Given this list of marker genes DIMT1, SCAI, ROR1, SSH2, AGPS, ATF1, KLHL24, HIF1A, BPNT2, SH3GLB1, PRRC1, PCDHB15, YWHAZ, SHPRH, FAM177A1, REV1, SLC9A1 (solute carrier family 9 member A1), DPY19L1, SLC19A2, ZNF704, MYC, B3GAT1 (NCBI Gene Id 964), ARGLU1, LEMD3, KLHL15, KPNA4, PALM2AKAP2, TRHDE, DYRK1A, TGDS, IRX2, UBE2D1, ZNF382, NAP1L1, CADM2, IGFBPL1, GPR155, IGFBP3, HYCC1, NSD2 (NCBI Gene Id 7468), ADNP, SREK1IP1, ABI1, ZNF682, TRIP12, PTPDC1, UBAC2, LIN7C, USP38, TET2, TMEFF2, CXCR4, SLC4A10, CNTNAP2, ABCA5, SORBS1, RANBP3L, TET3, PPM1K, CELF2, PIK3R3, VASP, ACVR1, GPC4, TC2N, CAMTA1, DYRK2, ARL14EP, UBN2, CBLL1, TTYH2, TCF7L2, CREBRF, EIF5A2, SKI, TBL1XR1, SMURF2, ZFHX3, USP46, HPS1, PIK3R1, ZEB1, GPATCH2, ZC3H12C, NRIP1, USP15, CTDSPL2, GPC6, SERTAD2, SERINC3, PTPRK, AKAP5, PTBP2, CLDN11, MTSS1, MARCHF4, SGMS1, PFKFB2, KANSL1L, MARCHF5, CDYL, FBXW2, COA5, PARP15, BEND4, FERMT2, INPP4A, TFPI2, PTPRZ1, CECR2, ZMPSTE24 (NCBI Gene Id 10269), MAFG, SRFBP1, OAS3, EPG5, ABHD13 (abhydrolase domain containing 13), LPP, MMD (NCBI Gene Id 23531), DIP2B, CD38, L2HGDH (NCBI Gene Id 79944), RANBP1, ABLIM2, YES1, SNW1, FGFR3 (NCBI Gene Id 55546), SAR1B, GNL3L, USP49, CCDC71L, AMER2, KCMF1, DNMT1, APH1A, FOS, PDE7A, SH3TC2, SLC38A1, TRIM36, GTF2B, NAA15, SLC16A7, SFPQ, NEK7, LHX9, MAPK8, MYBL1, GNB4, PPFIA1, SUZ12, DLEU7, SNX16, SAMD8, DTD1, SEH1L, FAM83B, HYCC2, SLC25A44, FARP1, RIMKLB, CSNK1A1, SINHCAF, DPP10, ZDHHC17, SCYL2, TOX, CTNND1, NAMPT, ADGRE2, PSD3, TMEM41B, EREG, YTHDF1, MSTN, RBPJ, SPOCK3, VPS13C, CYP2U1, ZBTB44, PRMT1, PTBP3, NAA50, SERPINB1, FBXL20, ZNF609, RAF1, TRIM33, SIDT2 (NCBI Gene Id 51092), DIS3L2, ST6GAL1, STRA6, RPRD1A, SOS2, ZDBF2, TOMM70, FOXP2, NUFIP2, ARID1A, EVI5, CPNE8, FLI1, ANKRD13C, MMADHC, MRPS11, LSM8, MAF, KNTC1, ZEB2, TMPO, NPM3, BRD10, VCPIP1, FBXO11, RSPRY1, USP24, ZFAND5, TVP23B, HNRNPR, HMGN1, SOX21, ADH7, HIPK2, PCDH20, PKD2, KIAA1210, LPCAT2, AOX1, MCU, RNGTT, CYP4V2, CCNYL1, NIN, DCP1A (NCBI Gene Id 55802), ZBTB2, B3GALT2, MED30, USP10, CCNT1 (NCBI Gene Id 904), ERBIN, VAPA, KCNQ5, AZIN1, PHACTR2, ELOVL4, DTNA, HOXA5 (NCBI Gene Id 55953, homeobox A5), PPP1CC, GKAP1, FRS2, LRATD2, PAK2, PGR, ANKS1A, KRAS, GTDC1, MICU3, DLG1, ANO5, SECISBP2L, DYNC1LI2, DAZ1, FAT1, CNOT6L, TLDC2, VKORC1L1, ZNF740, GSE1, TGFBR1, DCK, ICAM5, RASEF, SSU72 (NCBI Gene Id 79588), USP53, TMCO1, UTRN, FOXN2, TMEM50A, ANKIB1, P3R3URF-PIK3R3 (P3R3URF-PIK3R3 readthrough), PDS5B, HOXA3, CNEP1R1, LZIC, GABPB1, TGS1, XPR1, C5orf24, ACSL3, MAP4, GABBR2, ZNF24 (zinc finger protein 24), FGD6, SLCO5A1, PLEKHM3, ARL6IP5, TLNRD1, SHISAL1, ASPH, GGCX, DCAF12L1, ATXN1, HMGXB4, AVL9 (NCBI Gene Id 23080), ZNF365, PPAT, MBNL3, SPTSSA, VPS4B, MPZL1, MED1, USP42, ZNF562, ZNF322, AAGAB, ARID4A, RPL34, BNIP2, KDM7A, FBXL17, TFDP1, GFPT1, SLC4A7, MARK1, ZNF236, RC3H1, ARHGAP32, COL4A1, EIF4B, DHX32, COMMD9, OSBPL8, DDX4, WDR37, NLGN1, YBX1, PHF14, GTF2I, SLC2A13, TMEM64, MOSPD1, MINDY2, DNAJB5, CLGN, BCAR1, NEXMIF, EYA3, PPP4R3A, SBSPON, GAB1, TRPC1, PAN3, ETS1, CPEB3, VEZF1, DDA1, MCTS1 (NCBI Gene Id 28985), ITPRIPL2, RNF19A, NET1, SLC35D1, AAK1, OAF (out at first homolog), FBXO43, EFEMP1, RBM27, MYEF2, ABHD2, KIAA0408 (NCBI Gene Id 9729), ADGRB3, FZD1, RGS13, ZNF706 (zinc finger protein 706), SOST, ORC4, TMEM170A, PLPPR4, REDIC1, PLAC8L1, GABRA4, LIN7A, STRN3, SKIL, PTH2R, MANEA, FSBP (fibrinogen silencer binding protein), AMFR, NOVA1, ERGIC2, RPS6KA6, MCF2L2 (NCBI Gene Id 23101), RYK, USP37 (ubiquitin specific peptidase 37), NKX2-1, FRMD5, EPC1, LIG4, PRKAR1A, MED12, SLC7A11, PAG1, TBC1D22B, ZNF468, TM7SF3, MCL1, ACVR1C, ANLN, SMC2, DMRTA1, PPP2R5E, AKR1D1, C21orf91, GABRB3, FGF12, QKI, RAC1, RBBP4, PPP4R2, ZNF652, RPS3, SP4, GLCE, WNK3, DYNLT3 (NCBI Gene Id 6990), DAZ4, DICER1, PCGF5, TBL1X (transducin beta like 1 X-linked), RAB3C, TJP1, DCLK1, IPMK (inositol polyphosphate multikinase), RBBP9, CIP2A, WDR44, NHLH2, MME, RBMS3, TNPO1, MMGT1, SOX2, SLC12A2, TMED2, MEX3B, ACBD5, KLHL5, PRKCB, GPR63, NR2C2, SMARCA5, RBM12B, SOX6, RBM24, CAMSAP2, CPEB4, ACTR3B, BDP1, OSTM1, SCN9A, ACVR2B, GNG2, DBI, SLC18B1, VGLL3, FYTTD1, ASAP1, MAPK6, HDX, INO80D, NPM1, PROSER1, NCOR1, PIK3CA, DENND1B, PRMT3, MBTD1, PRKAA2, G3BP1, CCZ1B, RORA, PPP6C, RSBN1, EXOSC9, APPBP2, MAP3K2, FZD3, MIB1, AGBL3, ADAM17, BCOR, AHSA2P, TP53INP1, TBP, PHF20L1, PLD5, PTPRD, FER, GABRB2, AFAP1, CD47, PRPF6, CARF, UFM1, TTC14, DNAJC19 (DnaJ heat shock protein family (Hsp40) member C19), PUS7, KLHL11, GTF3C4, ATF7IP, GABRG1, PURG (NCBI Gene Id 29942), ANO4, HNRNPF, ANKH, MEF2C, KCTD12, MTCL3, N4BP2L2, ZNF750, GTF2A1, SELENOI, ZNF280D, ATP2A2, COL1A1, PTPN5, NAPG, DUSP15, FLRT2, BAG5, NAB1, IGF2BP3, PRKCA, ZNF367, NFYA, SMIM8, DPP8, AP1AR (NCBI Gene Id 55435), RNF180, PCDH11X, UBXN2B, SASS6, CCNA2, MARCKSL1, ATRNL1, DCBLD2, NANOGNB, GSPT1, HERPUD2, DAZ2, MED13, ZNF148, PDE4D (phosphodiesterase 4D), RPS6KA3, OXGR1, B4GALT6, PNISR, LLGL2, CRY1, SCG2, SKAP2, PSIP1, ARL5A, CDK17 (NCBI Gene Id 5128), GCLC, UBE2W, TAF5, BLOC1S2, LIN28B, SLC23A2, UBR5, ARL6IP6, TIGD3, DACT1 (NCBI Gene Id 51339), DUS4L, MPHOSPH9, MCTP1, B4GALT4, JAK2, KDELR1, MED6, HDAC9, BACE1, SUFU (SUFU negative regulator of hedgehog signaling), ZNF561, MED13L, OTUD7B, GORAB, CNST, USP13, SON, YIPF4, AGR3, MAP2, KMT2D, ZSWIM6, NOTCH2, PUM2, HDAC4, IRAK2, PM20D2, SOCS6, TSC22D2, ETNK1, TIAL1, SPIRE1, LCOR, CFAP61, SETBP1, ZFR, ALCAM, AFF1, NTF3, ASAP2 (ArfGAP with SH3 domain, ankyrin repeat and PH domain 2), ANKRD28, SLC25A36, SNRPD1, SYNCRIP, DCAF17, CKAP2, EMC1, YIPF6, TAOK1, CYP8B1, ATP2B4, TOX3, STOX2, ZMYM3, NUP62CL, GNAI3 (G protein subunit alpha i3), ERO1B, STK24, MAPKAPK2, SLC25A16, PLAGL2, SLC17A2, SIAH2, ABCD4, PARD3, CCL3L3, AGO2, NOL4, PSMA1, RIT2, ELAVL1, SYT4, MBNL1, PHIP, IKZF2, ING3, USP25, PDE10A, ZNF678, MFAP2, RAB23, CREB1, ZNF469, FAM241A, ARFGEF3, HBEGF, PPP2R2B, SMIM13, PDE1A, ARAP2, RBM47, THSD7B, MOB1B (MOB kinase activator 1B), FAM220A, RNF139, CCZ1, COQ10A, TUT4, YTHDF3, GRIA2, CCDC73, IQGAP2, CPEB1, CDKN1B, PLEKHB2, CDK6, DNMT3B, ZNF326, C2orf49, ST6GALNAC5, SOCS5, NABP1, UGGT1, G2E3, C12orf75, RAD54B, CNOT7, MDFIC, SLC30A7, CRISP1, UBXN4, IGSF5, CCND1, MAML3, BCLAF3, SUB1, ERBB2, CPSF6, HECTD2, INPP5F, FHDC1, MAP2K4, PYGO1, SMC5, RNF217, FKBP5, ESRP1, BPTF (NCBI Gene Id 348241), ELMOD2 (ELMO domain containing 2), RBBP8, FSTL1, STAG2, PRSS35, DDX55, TMPRSS11F, SLC10A4, PRKCI, FAM169A, DCUN1D4, XRN2, ARK2N, JADE3, IFT56, PEX5L, CREM, ROBO1, RRP15, STRBP, RP2, DPY30, ZYG11B, PPP3CA, KCNJ2, TM2D3, AEBP2, PHC3, SUGT1, TVP23C, ZNF681, ICE2, ATL3, MCC, TMEM135, FMNL2, XRN1, APPL1, QTRT2, PELI1, DCDC2, PIGN, RECQL, FAM171B, RIMS1, SOAT1, TNRC6B, ZDHHC21, MOSMO, SPICE1, KDM5B, BTBD7, GPD2, EGR3, FYN, B3GALNT2, GAS1, ARHGAP29, UHMK1, HOXA9, ZBED4, DAZ3, STARD4 (StAR related lipid transfer domain containing 4), ZNF20, ETF1, SYT1, IDE, PDS5A, ATOSA, TXNRD3, DAG1, UBE2H, WASF1, here is a description of the gene set: Genes predicted to be targets of miRBase v22 microRNA hsa-miR-548j-3p in miRDB v6.0 with MirTarget v4 prediction scores > 80 (high confidence targets). Human Gene Set: MIR548J_3P species: Homo sapiens from publication Chen Y, Wang X (PMID 31504780)